Given this list of marker genes Trpc4ap, Sec63 (SEC63 homolog, protein translocation regulator), Nsun6 (NOL1/NOP2/Sun domain family member 6), Rad23b, Erc1, Pa2g4, Efnb1, H2ac13, Erbin, Rps18, Vps29, Bclaf1, Elovl7, H2ac10, Krit1, Mrpl38, Tmc4, Smg6, Dnajc5 (NCBI Gene Id 99185), Lrrc46, Atp7a, Rtn4 (reticulon 4), Polr3f, Fgd1, Wdr45b, Kcnh1, Sfn, Lpgat1, Mettl1, Fzd10, Tomm40, here is a description of the gene set: studied in species Mus musculus from publication Terao M, Kurosaki M, Barzago MM, Fratelli M, Bagnati R, Bastone A, Giudice C, Scanziani E, Mancuso A, Tiveron C, Garattini E (PMID 18981221) The mouse aldehyde oxidase AOH2 (aldehyde oxidase homolog 2) is a molybdoflavoenzyme. Harderian glands are the richest source of AOH2, although the protein is detectable also in sebaceous glands, epidermis, and other keratinized epithelia. The levels of AOH2 in the Harderian gland and skin are controlled by genetic background, being maximal in CD1 and C57BL/6 and minimal in DBA/2, CBA, and 129/Sv strains. Testosterone is a negative regulator of AOH2 in Harderian glands. Purified AOH2 oxidizes retinaldehyde into retinoic acid, while it is devoid of pyridoxal-oxidizing activity. Aoh2(-/-) mice, the first aldehyde oxidase knockout animals ever generated, are viable and fertile. The data obtained for this knockout model indicate a significant role of AOH2 in the local synthesis and biodisposition of endogenous retinoids in the Harderian gland and skin. The Harderian gland's transcriptome of knockout mice demonstrates overall downregulation of direct retinoid-dependent genes as well as perturbations in pathways controlling lipid homeostasis and cellular secretion, particularly in sexually immature animals. The skin of knockout mice is characterized by thickening of the epidermis in basal conditions and after UV light exposure. This has correlates in the corresponding transcriptome, which shows enrichment and overall upregulation of genes involved in hypertrophic responses. Mouse Gene Set: TERAO_AOX4_TARGETS_SKIN_UP Genes up-regulated in skin upon knockout of AOX4.